The following is a description of a gene set: Catalysis of the movement of phospholipids from one membrane bilayer leaflet to the other, by an ATP-independent mechanism. Human Gene Set: GOMF_PHOSPHOLIPID_SCRAMBLASE_ACTIVITY species: Homo sapiens, and this is the list of marker genes: VMP1, PLSCR5, VDAC2, TMEM63A, ATG9A, CLPTM1L, XKR8, PLSCR2, SERINC5, TMEM63B, ANO6, PLSCR4, TMEM63C, ANO3, SERINC2, XKR4 (NCBI Gene Id 114786), TMEM41B, SERINC3, ATG9B, PLSCR1, XKR9, PLSCR3, ANO9, ANO4